The following is a description of a gene set: Shoulder contracture Human Gene Set: HP_SHOULDER_CONTRACTURE Lack of full passive range of motion (restrictions in flexion, extension, or other movements) of the shoulder joint resulting from structural changes of non-bony tissues, such as muscles, tendons, ligaments, joint capsules and/or skin. studied in species Homo sapiens, and this is the list of marker genes: RNU4ATAC, MYL11, MYH3, KY, COL6A2, SCN4A, TNNT1, HSPG2, COL12A1, JAG2, FILIP1, GNPTG